Given this list of marker genes ATG4A, CDC37, NIPSNAP3B, EIF2S1, RETREG1, WDR45B, UBE2A, ATG9A, SQSTM1, BNIP3L, SNX7, ATG2A, ADCY10 (adenylate cyclase 10), CTSK, ATG2B, FUNDC2, GABARAP, WIPI1, ATG13, FZD5, OGT, MAP1LC3A, TSC2, ABI2, BCL2L13, SREBF2, ATG4C, CLEC16A, ATG7, ATG10, ARHGAP26, CTTN, CAMKK2, NIPSNAP3A, RBX1, VPS13C, NIPSNAP2 (NCBI Gene Id 2631), USP36, MAP1LC3B, TOMM7, STUB1, EIF2AK1, ATG4D, HTT, CSNK2A2, WIPI2, HUWE1, HK2, VPS13D, BECN2 (NCBI Gene Id 441925), GABARAPL2, SPATA18, PARK7, GABARAPL1, BECN1, TIGAR, PARL, MAP1LC3B2, DNM1L, LRBA, IRGM, GBA1, DELE1, SNX30, PHB2, RNF41, SLC25A5 (solute carrier family 25 member 5), ARFIP2, AMBRA1, ULK2, ATG3, SPATA33, CDKN2A, USP30, MARK2, MFN2, ATG12, HAX1, PRKN, TIMM23, FUNDC1, ATG9B, HTRA2, CERS1, ATP5IF1, ULK1, GABARAPL3, VDAC1, FBXW7, ULK3, NIPSNAP1, ATG14, MAP1LC3C, FKBP8, FBXO7, GSK3A, ATP13A2, TSPO, WDR45 (NCBI Gene Id 11152), MUL1, NOD2, SLC25A46, SLC25A4, PINK1, HDAC6, BNIP3, RB1CC1 (RB1 inducible coiled-coil 1), TP53, PPTC7, CISD2, FBXL4, SREBF1, ATG4B, RIMOC1, ATG5, OPTN, here is a description of the gene set: The autophagic process in which mitochondria are delivered to a type of vacuole and degraded in response to changing cellular conditions. species: Homo sapiens Human Gene Set: GOBP_AUTOPHAGY_OF_MITOCHONDRION